Given this list of marker genes UBE2D1, HDAC1, TGIF2, NCOR1, USP9X, PPM1A, MAPK1, SNW1, MAPK3, SMAD7, TRIM33, UBC, SMAD3, SKIL, TGIF1, UBB, RPS27A, WWTR1, SERPINE1, UBA52, SMURF2, STAT1, ATP1B4, SMAD4, SKI, RNF111, PARP1, SMAD2, NEDD4L, NCOR2, UBE2D3, here is a description of the gene set: Reactome Pathway: Downregulation of SMAD2/3:SMAD4 transcriptional activity Transcriptional activity of SMAD2/3:SMAD4 heterotrimer can be inhibited by formation of a complex with SKI or SKIL (SNO), where SKI or SKIL recruit NCOR and possibly other transcriptional repressors to SMAD-binding promoter elements. Higher levels of phosphorylated SMAD2 and SMAD3, however, may target SKI and SKIL for degradation through recruitment of SMURF2 or RNF111 i.e. Arkadia ubiquitin ligases to SKI/SKIL by SMAD2/3. Therefore,the ratio of SMAD2/3 and SKI/SKIL determines the outcome: inhibition of SMAD2/3:SMAD4-mediated transcription or degradation of SKI/SKIL. SKI and SKIL are overexpressed in various cancer types and their oncogenic effect is connected with their ability to inhibit signaling by TGF-beta receptor complex. <br>SMAD4 can be monoubiquitinated by a nuclear ubiquitin ligase TRIM33 (Ecto, Ectodermin, Tif1-gamma). Monoubiquitination of SMAD4 disrupts SMAD2/3:SMAD4 heterotrimers and leads to SMAD4 translocation to the cytosol. In the cytosol, SMAD4 can be deubiquitinated by USP9X (FAM), reversing TRIM33-mediated negative regulation.<br>Phosphorylation of the linker region of SMAD2 and SMAD3 by CDK8 or CDK9 primes SMAD2/3:SMAD4 complex for ubiquitination by NEDD4L and SMURF ubiquitin ligases. NEDD4L ubiquitinates SMAD2/3 and targets SMAD2/3:SMAD4 heterotrimer for degradation. SMURF2 monoubiquitinates SMAD2/3, leading to disruption of SMAD2/3:SMAD4 complexes. <br>Transcriptional repressors TGIF1 and TGIF2 bind SMAD2/3:SMAD4 complexes and inhibit SMAD-mediated transcription by recruitment of histone deacetylase HDAC1 to SMAD-binding promoter elements.<br>PARP1 can attach poly ADP-ribosyl chains to SMAD3 and SMAD4 within SMAD2/3:SMAD4 heterotrimers. PARylated SMAD2/3:SMAD4 complexes are unable to bind SMAD-binding DNA elements (SBEs). <br>Phosphorylated SMAD2 and SMAD3 can be dephosphorylated by PPM1A protein phosphatase, leading to dissociation of SMAD2/3 complexes and translocation of unphosphorylated SMAD2/3 to the cytosol. species: Homo sapiens part of: Transcriptional activity of SMAD2/SMAD3:SMAD4 heterotrimer